The following is a description of a gene set: Palmar hyperhidrosis Human Gene Set: HP_PALMAR_HYPERHIDROSIS species: Homo sapiens, and this is the list of marker genes: ADAMTS15, CTSB, LAMB3, RSPO1, KRT16, KRT17, TRPV3 (NCBI Gene Id 201131), SERPINB7, PLAA, CDSN (corneodesmosin), KRT6B, KRT6A, CFTR, PERP, WNT10A, MBTPS2